Given this list of marker genes LUC7L, IGFBP5, LEF1, FGF3, TWIST1, FGF8, USP19 (ubiquitin specific peptidase 19), SOX15, TGFB1, BMP4, SIRT2, YBX3 (NCBI Gene Id 8531), here is a description of the gene set: Human Gene Set: GOBP_NEGATIVE_REGULATION_OF_MUSCLE_TISSUE_DEVELOPMENT studied in species Homo sapiens Any process that stops, prevents or reduces the frequency, rate or extent of muscle tissue development.